The following is a description of a gene set: Any process that modulates the frequency, rate or extent of establishment of protein localization to mitochondrion. Mouse Gene Set: GOBP_REGULATION_OF_ESTABLISHMENT_OF_PROTEIN_LOCALIZATION_TO_MITOCHONDRION studied in species Mus musculus, and this is the list of marker genes: Lrrk2, Fbxw7, 4930550C14Rik, Pmaip1, Gsk3a (glycogen synthase kinase 3 alpha), Nol3, Dnaja1, Atp5if1, Bag4, Adcy10, Tomm70a, Mapt, Srebf1, Siah3, Prkaa1, Bbc3, Pdcd5-ps, Tomm7, Bnip3l, Pink1, Cdkn2a, Hspa1l, Ptpn5, Parl, Pdcd5, Bag3, Sh3glb1